The following is a description of a gene set: Reactome Pathway: Recycling of eIF2:GDP The active eIF2:GTP complex may be formed by direct binding of GTP to free eIF2 or by GDP-GTP exchange on the eIF2:GDP:eIF2B complex. The eIF2:GDP complex binds eIF2B forming an eIF2:GDP:eIF2B intermediate complex. eIF2B is a guanine nucleotide releasing factor required to cause GDP release so that a new GTP molecule can bind and activate eIF2. Phosphorylated eIF2:GDP sequesters all eIF2B as an inactive complex, and thus, reuse of eIF2 is inhibited as a consequence of the tight bond it forms with eIF2B, which prevents nucleotide exchange. Therefore, in the absence of free eIF2B, excess eIF2 remains in its inactive GDP-bound form and protein synthesis slows dramatically. part of: Cap-dependent Translation Initiation species: Homo sapiens, and this is the list of marker genes: EIF2B1, EIF2B3, EIF2S2, EIF2S1, EIF2S3, EIF2B4, EIF2B5, EIF2B2